The following is a description of a gene set: Catalysis of the reaction: NAD(P)+ + androsterone = NAD(P)H + H+ + 5-alpha-androstane-3,17-dione. Mouse Gene Set: GOMF_ANDROSTERONE_DEHYDROGENASE_NAD_P_PLUS_ACTIVITY studied in species Mus musculus, and this is the list of marker genes: Akr1c12, Akr1c19, Rdh5, Akr1c14, Rdh9, Rdh16f2, Akr1c21, Akr1c20, Rdh16, Akr1c6, Dhrs9, Akr1c18, Rdh7, Hsd17b6, Rdh19 (NCBI Gene Id 216453), Rdh1, Akr1c13, Akr1cl